The following is a description of a gene set: Genes predicted to be targets of miRBase v22 microRNA hsa-miR-548h-3p, hsa-miR-548z in miRDB v6.0 with MirTarget v4 prediction scores > 80 (high confidence targets). Human Gene Set: MIR548H_3P_MIR548Z from publication Chen Y, Wang X (PMID 31504780) species: Homo sapiens, and this is the list of marker genes: CCNYL1, DCLK1, BCOR, CPEB2, TRHDE, RGPD1, SLC25A16, NUP98, CRLS1, RETREG1, USP24, ZFAND5, TAF9, ZC3H12C, SOAT1, BRD3, DNMT1, MLLT3, ZNF148, TMEM128, CDS2, RBL2, AFF2, LOXL2, TDRP, DNAJB1, GORAB, DNAL4, B3GALT2, RSRC1, ZNF830 (zinc finger protein 830), SPATA31A1, TNFSF11, ANKRA2, CDK14, SNX12, YTHDF1, CREBBP, UBE2H, DNAJB11, PRDM4, PITPNB, CNTLN, COL4A1, TCF7L2, PAPOLG, CCDC68, FAT1, ITPRIPL2, BARD1, YTHDF3, PXDN, DCUN1D4, UNC5D, SMIM10L1, RSPRY1, GRIA2 (NCBI Gene Id 2891), SYT16, GABRA4, PUM2, MFAP3L, MTRF1L, CSNK1G3, HDGFL2, ROBO1, HECTD2, LANCL3, USP16, NEK1, SYNCRIP, INPP4A, GPD2, SLC44A1 (solute carrier family 44 member 1), DOCK10, SETD3, SCG2, STIM2, ZFP30, KIRREL1, DLG1, STXBP4, MED13, NAA50, AZIN2, CABLES2, XPR1, PHC3, CPEB1, ADISSP, GOLM2, MCU, ZBTB34, NTF3, ATP2B2, MFSD14B, ZNF248, CCDC14, ERBIN, DCBLD2, PRKAR2B, ATP2B4, CLP1, CD47, ATXN7L3, RBM20 (NCBI Gene Id 282996), MBNL3, MYC, MLLT1, NCL (NCBI Gene Id 4691), YBX1, MBTD1, MITF, PTPRZ1, NOL7, PCDH20 (NCBI Gene Id 80245), AEBP2, CCDC71L, CRY1, SCYL2, SEMA4B, TRIM28, SUZ12, VAV2, CHUK, AGPAT1, TUT7, LLGL2, ATP6V0A2, XIAP, FOSL2, SKI, ZNF529, TMC7, ABCC2, USP42 (NCBI Gene Id 84132), TBX3, UBE2D1, IRX2, PDCD7, BCL2L11, SELENOI, FSBP, ARID4A (NCBI Gene Id 5926), RB1, ICE2, ZNF547, PDE1C, USP49, CADM2, CAMSAP2, DYRK2, ARHGAP29, SNX18, ANO3, WWC3, ERO1B, HOXD13 (NCBI Gene Id 7859), AMFR, SETD7, FBXW2, SPATA31A3 (NCBI Gene Id 727830), USP38, SNRK, ARL6IP5, SHISAL1, EGR3, IGF2BP2, LOXL1, LRRC8C, SEMA6D, RPS6KA3, DPY30, HIF3A, TSPAN3, MXD1 (MAX dimerization protein 1), ADGRG2, HNRNPR, RASA2, WDR44, MGARP, HYCC2, EFEMP1, SLC18B1, ROR1, ELAVL1, PTBP2, SAR1B, VGLL3, IPO8, TP53INP1, SRP54, SLC25A44, B4GALT4, STOX2, FIGNL1, HIPK2 (homeodomain interacting protein kinase 2), SGO2, DNAJA2, COL1A1, ZNF566, DIS3L2, GTF3C4, ITPA, RICTOR, ANO5, HUS1, TMPO, HOXB7, AKT1, RNPC3, ATL3, RBPJ, TFPI2, TOX3, ATF7IP, KDM7A, TLNRD1 (talin rod domain containing 1), MEF2C, STARD4, SPATA31A7, NOL10 (nucleolar protein 10), KIAA0408, PDS5A, HOXA5, SCUBE2, RUNDC3B, SORCS1, C5orf24, STX16, PRMT3, TGFBR1 (transforming growth factor beta receptor 1), PIK3CA, ERI1, MEX3C, B3GNT5, TAF7L, FSD1L, CCZ1, ELMOD2, ARID1A, PDSS2, ZNF704, ERGIC2, FOXN2, RASEF, PITPNM2, YIPF4, TET3, HELZ, HOOK3, PI4K2B, AKAP10, TSPAN9, PID1, LRRC37B, OSGEP, MAPK1, ZNF468, DDX5, UGCG, FMNL2, IKZF2, YBX3, CTXN2, NAALADL2, PPP1R2, CA13, WNT5A, BTBD10, SSR1, TANK, RBBP4, MAPK6, MCL1, EREG, ZCCHC14, ZBTB22, MATR3, ABHD13, GFPT1, SOS2, WWP1, FKBP5, IDS, MAP3K3, ICAM5, MAPK8, VKORC1L1, IER3IP1, RB1CC1, MOB4, RIT2, PPP2R1A, ZBTB21, PTPRK, HSPE1-MOB4, STAC, ARL6IP6, DTNA, KIAA0232, ALKBH1, SON, ABI2, DMD, SPTSSA, G2E3, KRTAP2-4, INVS, MYBL1, RSBN1, KMT2C, ARX, MOB1B, MAGOHB, MYLK, GPATCH2, ING3, AZIN1, ZDHHC21, ZNF583, RIF1, CNOT6L, ZNF28, EIF4G2, CXCL12, GTF2A1, KCTD12, CYRIB, RMI1, FYTTD1 (NCBI Gene Id 84248), TLL1, OTUD7B (NCBI Gene Id 56957), CD96, SCAI, ZBTB41, DNAJB4, SIAH2, SMIM7, MCM9, BPTF, NAMPT, POLD3 (DNA polymerase delta 3, accessory subunit), PANK1, TMEM131, FZD3, CPNE8, UBR5, PPM1B, CARF, RCAN2, MAP3K7, HSPH1, RORA, ETF1, LPGAT1, SOX6, ADARB2, SFPQ, GPR63, BBS9, SPATA6, PRMT1, CCND2, NPAS3, SMG7, MARCKSL1, CDK17, LETM2, ENTPD7, RBM46, MAML3, DUS4L, KRAS, SOHLH2, RBM27, ZNF207, TTC14, SPATA31A6, TBL1XR1, KIN, NRIP1, RETSAT, GNA11, CSNK1A1, GABPA (NCBI Gene Id 2551), LARP4, MARCHF5, GRIN3A, C2CD2, PIK3R3, API5, BPNT2, CPSF6, ZNF875, ZNF614, SMC1A, IL6, ANKRD13C, EIF1AX, SPATA31A5, CIPC, PM20D2, ALK, CCNC, CSNK2B, CREBRF, FHIP1A, SLC30A7, GIGYF1, TMPRSS15, TMEM64, ZNF800, ZBBX, BACH2, BOLL, SUPT3H, RASD1, PMS1, PLGRKT, ATP2A2, QTRT2, SOCS6, COX15, YPEL5, TUT4, HDAC8, GNAI3, NDUFA4, SOCS5, SKIL, MDM4 (NCBI Gene Id 4194), UBN2, CPEB4, ZNF648, GMCL1, MMGT1, HUWE1, ANKRD28, PTBP3, FLI1, RABEP1, ACBD5, PIM1, ONECUT2, TMEM170B, ZBTB8A, PIK3R1, SGCZ, ERP44, PDCL3, TCP11L2, KCNJ2, MBOAT2, ZMPSTE24, EGLN1, EMP2, KLHL15, SLC10A4, RNFT2, LAMTOR1, AGL, FAM76B (family with sequence similarity 76 member B), RBMS3, HDAC4, MAP2K4, SPIN1, PRR14L, UTRN, IL6R, GCFC2, ETNK1, BCL2L10, SCN9A, LIN7C, SH3RF1, YWHAZ, PPP1R14B, TMEM59, CASC3 (CASC3 exon junction complex subunit), TOX, BAG5, LIN28B, ACVR1C, ZMIZ1, MOSMO, KDM2A, LRFN3, EPC1, FKBP1A, RAF1, HMGCS1, PAN3, SBK1, LEPROTL1, PDE7A, TBCA, PRKAA2, PARP11, PELI2, ARFGEF3, SDK1, FZD6, PLPP2, CMTM6, STRN3, NAA35 (NCBI Gene Id 79688), ZFAND4, COPS2, TTC28, C18orf54, CNOT7, AHSA2P, KLF11, HDX, NUFIP2, FAM169A, TRMT9B, PLAGL2, GABRG1, HNRNPC, RAPH1, MARK1, SLC35A3, SIDT2, DOCK6, SPRED1, DDX6, ARGLU1, DAG1, SERBP1, LRRC58, ANKS1A, OTX2, MAP3K5, GPC6, STOML2, CACNA2D1, SMC1B, INO80D, RP2, CAMTA1, SEPTIN2 (septin 2), BMPR1A, TMEM63B, DYRK1A, ELOC, WNK3, DNMT3B, RC3H1, MID1, PSD3, MAFB, TM2D3, MSI2, GRPEL2, SAMD8, IQGAP2, COLGALT2, SASH1, SYT4, TAOK1, LRRTM4, NOTCH2, NAV2, RCC1L, VCPIP1, GSE1, UHRF1, L2HGDH, APH1A, BROX, PITPNM3, VSTM2A, ATP13A3, STK24, TNRC6B, SLC2A13, DOCK9, DNAJB12, SLF2, CNOT9, LSM14A, TSLP, PSIP1, UHMK1, CCDC34, PRKCI, ZMYM3 (NCBI Gene Id 9203), RPS6KA6, MPZ, RNF38, MED1 (NCBI Gene Id 9327), GABBR2, POU3F1, FANCC, SAP130, MYEF2, TMCC1, TSC22D2, HOXD8, DND1, SETBP1, KPNA4, MTMR4, MFSD13A, VEZF1 (vascular endothelial zinc finger 1), ARAP2, CCZ1B, SMURF2, PELI1, POLR1A